Given this list of marker genes ADAM32, FETUB, TEX101, ACR, CCT3 (chaperonin containing TCP1 subunit 3), ZAN, ALDOA, TMPRSS12, ZP1, ADAM2, ATP8B3, SPA17, PAEP, CRISP1 (cysteine rich secretory protein 1), CCT7, ZP4, ZP2, SPAM1, ASTL, HSPA1L, ADAM18, CCT2, LY6K, GARIN3, CLGN, TCP1, B4GALT1, PCSK4, OVGP1, ZPBP, ZP3, VDAC2, PRSS37, CCT8, PRSS55, UBAP2L (NCBI Gene Id 9898), SPACA4, CCT5, ZPBP2, IZUMO1, CCT4, here is a description of the gene set: species: Homo sapiens Human Gene Set: GOBP_BINDING_OF_SPERM_TO_ZONA_PELLUCIDA The process in which the sperm binds to the zona pellucida glycoprotein layer of the egg. The process begins with the attachment of the sperm plasma membrane to the zona pellucida and includes attachment of the acrosome inner membrane to the zona pellucida after the acrosomal reaction takes place.